Given this list of marker genes Ctnnbip1, Cacybp, Ctnnb1, Siah1b, Gsk3a, Apc (NCBI Gene Id 11789), Axin1, Axin2, Dact1, Gsk3b, Apc2, Siah1a, Csnk1a1, here is a description of the gene set: species: Mus musculus A cytoplasmic protein complex containing glycogen synthase kinase-3-beta (GSK-3-beta), the adenomatous polyposis coli protein (APC), and the scaffolding protein axin, among others; phosphorylates beta-catenin, targets it for degradation by the proteasome. Mouse Gene Set: GOCC_BETA_CATENIN_DESTRUCTION_COMPLEX